The following is a description of a gene set: Human Gene Set: GOBP_POSITIVE_REGULATION_OF_MACROPHAGE_DERIVED_FOAM_CELL_DIFFERENTIATION Any process that increases the rate, frequency or extent of macrophage derived foam cell differentiation. Macrophage derived foam cell differentiation is the process in which a macrophage acquires the specialized features of a foam cell. A foam cell is a type of cell containing lipids in small vacuoles and typically seen in atherosclerotic lesions, as well as other conditions. species: Homo sapiens, and this is the list of marker genes: PLA2G3, MAPK9, AGTR1, PRKCH, PLA2G2A, PF4, AGT, CD36, CSF1, PLA2G10, NFKB1 (nuclear factor kappa B subunit 1), LPL, TNF, IL1B (NCBI Gene Id 3553), APOB, IL18, ALOX15B, PLA2G5, MIR185, MSR1, CSF2